The following is a description of a gene set: Beta-catenin independent WNT signaling Mouse Gene Set: REACTOME_BETA_CATENIN_INDEPENDENT_WNT_SIGNALING studied in species Mus musculus, and this is the list of marker genes: Gngt1, Ppp3r1, Psmc2, Adrm1, Ppp3ca, Gng11, Prkcg, Ubb, Pde6g (phosphodiesterase 6G, cGMP-specific, rod, gamma), Gnb2, Rps27a, Ctnnb1, Gng5, Psma7, Calm3, Psma2, Pard6a, Cltc, Pde6b, Map3k7, Kras, Gnb4, Calm1, Psmc5, Ap2b1, Psmd2, Psma4, Gnat2, Daam1, Psmb6, Tcf7l1, Psma6, Psmd12, Ap2a2, Fzd5, Gng10, Psma1, Gnb1, Gng12, Psmd6, Psmd8, Psmb2, Gng4, Tcf7, Uba52, Fzd7, Psma5, Gng8, Fzd1, Wnt11, Ap2s1, Dvl3, Psmd1, Cltb, Psmd3, Fzd3, Ap2m1, Nlk, Smurf2, Fzd6, Pfn1, Psmb5, Ror1, Gng13, Prkcb, Fzd4, Psmb7, Gng2, Nfatc1, Gnb5, Psmd7, Camk2a, Dvl2, Wnt4, Psmc1, Rhoa, Prickle1, Plcb2, Psmb1, Psmd13, Gng7, Wnt5b, Fzd2, Wnt5a, Plcb1, Rac1, Wnt1, Ppp3cb, Rac3, Psmc4, Fzd8 (frizzled class receptor 8), Rac2, Dvl1, Arrb2, Psmc3, Psmd14, Psmc6, Psmd11, Psmb4, Clta, Ubc, Psmb3, Plcb3, Gngt2, Gnao1, Ap2a1, Psma3, Uba52rt, Gnb3, Calm2, Gng3, Tcf7l2, Smurf1, Lef1